Given this list of marker genes HGS, UBB, VPS33B, RAB7A, UBA52, UBC, RAB5A, RPS27A, CORO1A, here is a description of the gene set: Prevention of phagosomal-lysosomal fusion Human Gene Set: REACTOME_PREVENTION_OF_PHAGOSOMAL_LYSOSOMAL_FUSION species: Homo sapiens